Given this list of marker genes AQP11, UGT8, IKZF5, RAB2B, ABCA1 (ATP binding cassette subfamily A member 1), DIXDC1, MBP, RNF13, OPCML, LRRN1, BRWD3, CDK6, CCNG1, TAL2, ABAT, BCAS3, IL6R, ENPP6, NARF, DSCAML1, NUMB, TNC, E2F1, ELMO1, PTDSS2, TNNI1, IKBKE, HBP1, PAK5, ATRN, TP53INP1, ZKSCAN1, MAP7, SLC25A27, KCNA1, SORBS1, RGS2, ANKRD6, NDRG1, EXT1, PAK3, OAS1, INPP5K, here is a description of the gene set: Oligodendrocyte core differentiation genes: up-regulated in Oli-neo cells (oligodendroglial precursor) at 10 h after treatment with PD174265, dexamethasone or isotretinoin. Inadequate remyelination of brain white matter lesions has been associated with a failure of oligodendrocyte precursors to differentiate into mature, myelin-producing cells. In order to better understand which genes play a critical role in oligodendrocyte differentiation, we performed time-dependent, genome-wide gene expression studies of mouse Oli-neu cells as they differentiate into process-forming and myelin basic protein-producing cells, following treatment with three different agents. Our data indicate that different inducers activate distinct pathways that ultimately converge into the completely differentiated state, where regulated gene sets overlap maximally. In order to also gain insight into the functional role of genes that are regulated in this process, we silenced 88 of these genes using small interfering RNA and identified multiple repressors of spontaneous differentiation of Oli-neu, most of which were confirmed in rat primary oligodendrocyte precursors cells. Among these repressors were CNP, a well-known myelin constituent, and three phosphatases, each known to negatively control mitogen-activated protein kinase cascades. We show that a novel inhibitor for one of the identified genes, dual-specificity phosphatase DUSP10/MKP5, was also capable of inducing oligodendrocyte differentiation in primary oligodendrocyte precursors. Oligodendrocytic differentiation feedback loops may therefore yield pharmacological targets to treat disease related to dysfunctional myelin deposition. from publication Gobert RP, Joubert L, Curchod ML, Salvat C, Foucault I, Jorand-Lebrun C, Lamarine M, Peixoto H, Vignaud C, Frémaux C, Jomotte T, Françon B, Alliod C, Bernasconi L, Abderrahim H, Perrin D, Bombrun A, Zanoguera F, Rommel C, Hooft van Huijsduijnen R (PMID 19139271) Human Gene Set: GOBERT_CORE_OLIGODENDROCYTE_DIFFERENTIATION species: Mus musculus